The following is a description of a gene set: Mouse Gene Set: GOBP_HYDROCARBON_METABOLIC_PROCESS The chemical reactions and pathways involving a hydrocarbon, a compound consisting of carbon and hydrogen only. studied in species Mus musculus, and this is the list of marker genes: Ephx1, Grin1, Cyp2f2, Ptgr1, Th, Bco1, Bco2